The following is a description of a gene set: Human Gene Set: REACTOME_SYNTHESIS_OF_VERY_LONG_CHAIN_FATTY_ACYL_COAS studied in species Homo sapiens Synthesis of very long-chain fatty acyl-CoAs, and this is the list of marker genes: HACD2 (3-hydroxyacyl-CoA dehydratase 2), HSD17B3, ELOVL3, HSD17B12 (NCBI Gene Id 51144), ELOVL2, ACSL4, TECRL, HACD1, ACSBG2, HACD4, ACSL3, SLC27A3, ELOVL1, ACSL6, ACSBG1, ELOVL5, TECR, HACD3, ELOVL7, ELOVL6, ELOVL4, ACSL1, ACSF3, ACSL5